Given this list of marker genes AASS, SLC3A1, SLC7A7, SLC7A9, LIPT1, here is a description of the gene set: Increased glutamine family amino acid level in urine Human Gene Set: HP_INCREASED_GLUTAMINE_FAMILY_AMINO_ACID_LEVEL_IN_URINE An elevated level of an glutamine family amino acid in the urine. studied in species Homo sapiens